Given this list of marker genes H2BC15, H2BC21, H2BC11, H2BC5, PRM1, NPM2, H3-3A, H4C1, H2BC12, METTL23, H2AX, PRM2, H2BC1, H2BC12L, H2BC4, HIRA, H2BC13, H2BC14, H2BC3, H2BC9, SRPK1, H2BC26, H1-8, H2BC17, here is a description of the gene set: part of: Maternal to zygotic transition (MZT) In human sperm, about 85 to 90% of the genome is associated with protamines rather than histones. Protamines provide a much higher packing density of DNA in the nucleus but there are few reports of epigenetic marks on protamines. After fertilization, protamines in the male pronucleus are replaced with histones provided by the oocyte cytoplasm. The result is a decondensation of sperm chromatin that produces a chromatin state that is permissive for transcription.<br>Dissociation of protamines from DNA appears to be controlled by phosphorylation of the protamines PRM1 and PRM2 (inferred from mouse homologs in Gou et al. 2020). The kinase SRPK1 phosphorylates both PRM1 and PRM2, which recruit the histone chaperones Nucleoplasmin 2 (NPM2) and HIRA (inferred from mouse homologs in Gou et al. 2020). NPM2 then dissociates the phosphorylated PRM1 from DNA. By inference NPM1 and NPM3, which are also present in the zygote, may also dissociate PRM1 and PRM2 from DNA.<br>Nucleosomes in the zygote are characterized by H3.3 and H2AX (H2A.X). HIRA chaperones histone H3.3 and acts together with NPM proteins to assemble nucleosomes from individual histone proteins. Asymmetric dimethylation of H3.3 arginine-17 catalyzed by METTL23 is required for assembly of H3.3 into chromatin in the male pronucleus (inferred from mouse homologs in Hatanaka et al. 2017). The oocyte-specific histone H1, H1FOO (H1.8, H1-8), is also deposited on the newly formed chromatin at this time and persists until the 8-cell stage. In mouse embryos, H1foo is not required for development. species: Homo sapiens Reactome Pathway: Replacement of protamines by nucleosomes in the male pronucleus